The following is a description of a gene set: Any complex of pre-rRNAs, ribosomal proteins, and associated proteins formed during ribosome biogenesis. studied in species Homo sapiens Human Gene Set: GOCC_PRERIBOSOME, and this is the list of marker genes: UTP18, RPS19BP1, AATF, NOP14, UTP23, TBL3, RPS24, BMS1, RPS6, RPS23, DHX37, RCL1, RPS17, WDR75, RRP15, RPS28, NOB1, UTP3, DIMT1, RPS16, FBL, PES1, MRTO4, NOL7 (nucleolar protein 7), KRR1, RRS1, SRFBP1, RPS12, MAK16, UTP25, UTP11, SNU13, NAT10, NOL6, RPS9, RRP1, KRI1, DNTTIP2, UTP14C, MDN1, WDR12, NOL10, ZNF622, FCF1, RPS14, C1orf131, RRP36, NOP56, NSA2, WDR43, PNO1, FTSJ3, UTP14A, NGDN, RIOK1, WDR46, RPS11, RPS5, WDR3, IMP3 (IMP U3 small nucleolar ribonucleoprotein 3), RPS13, RPS19, UTP4, RRP7BP, WDR36, EXOSC10, HEATR1, RPS27A, DCAF13, PWP2 (NCBI Gene Id 5822), RPS3A, RPS27 (ribosomal protein S27), EMG1 (NCBI Gene Id 619532), WDR74, NOP9, RRP1B, NOP58, PIN4, LTV1, RRP7A, RPS8, UTP20, UTP6, RPS15A, EBNA1BP2, MPHOSPH10, PRKDC, PDCD11, RIOK3, FBLL1, XRCC5, NIP7, RIOK2, IMP4, NOC4L, PPAN, NOC2L, SLX9, RPF1, RPS7, RPS4X (NCBI Gene Id 6191), UTP15, BOP1, RRP9, BYSL